The following is a description of a gene set: studied in species Homo sapiens from publication Schwartz JT, Bandyopadhyay S, Kobayashi SD, McCracken J, Whitney AR, Deleo FR, Allen LA (PMID 22986450) We demonstrated recently that both constitutive and FAS-triggered apoptosis of human neutrophils are profoundly impaired by Francisella tularensis, but how this is achieved is largely unknown. To test the hypothesis that changes in neutrophil gene expression contribute to this phenotype, we used human oligonucleotide microarrays to identify differentially regulated genes in cells infected with F. tularensis strain LVS compared with uninfected controls. In order to examine the effect of F. tularensis on the neutrophil transcriptome, we performed microarray expression analysis on human neutrophils treated with F. tularensis subsp. holarctica live vaccine strain (LVS). Genes up-regulated in comparison of control polymorphonuclear leukocytes (PMN) at 0 h versus PMN treated with F. tularensis vaccine at 6 h. Human Gene Set: GSE37416_0H_VS_6H_F_TULARENSIS_LVS_NEUTROPHIL_UP, and this is the list of marker genes: DUSP12, NSFL1C, ALG6, RNF135, NRDC, CD33, UBE2D1, EIF4E3, ARL6IP6, MSL3, FCGR3B, RESF1, NHS, RMI1, MANSC1, MCL1, CLEC4C, MIR21, SORT1, XRN2, APBB1IP, CEBPD, STX3, CCDC125, YWHAH, MPPE1, CREB5, SPINT1, TRERF1, UBR3, ZNF516 (zinc finger protein 516), DBI, PSMF1, HIPK3, H2BC9, MFSD14B, GNL3L, TRAPPC1, DPY19L3, FCGRT, GCNA, FAM8A1, RPS6KA3, USP48, HSPA8, GCA, USP32, RFNG, ICAM3, CX3CR1, MAP3K3, TMT1A, ZNF92, C1RL, GRAMD1C, MAP3K1, DPEP3, NRBF2, MTM1, KLHL8, PTRH2, NDUFB1, LMF2, ADAM19, PYGL, SULT1B1, ARHGAP1, IMPA2, NF1, GLUD1, BICD2, ATP13A1, INPP5B, ATF6, ZNF787 (NCBI Gene Id 126208), GAB1, KIAA0040, HK3, PARVG, CEP43, PTOV1, CHAC2, TCP11L2, CAPN1, WDFY3, TBC1D1, SCAMP1, TUBGCP3, SLC8B1, DEF8, ITGAL, CCDC126, TPST2, RASA1, RNF123, ITPR2, ZYG11B, RCBTB1 (RCC1 and BTB domain containing protein 1), SLC35A1, STK38, RPGRIP1, SMIM20, BTN3A1, TSC1, ANKRD44, RNF169, SECTM1, FCHO2, CASP2, ABHD18, AIF1, GAA, ITM2B, SMC1A, CAPRIN2, H2BC4, IRAG1, INTS3, C2CD2L, SLC25A44, VPS26B, PTPN18, KCTD21, USP6, DERA, TPM3, CZIB (CXXC motif containing zinc binding protein), JAK2, RAP1GAP2, CCNJL, FBXL5, SLC8A1, NASP, LIN37, NDUFB3, MMP25, CSAD, TLE4, CSNK1G3, INO80E, LRP10, APAF1, MSRB2, FCGR2C, SIN3B, ARSA, EVI5, EXOC6, NCKAP1L, CSNK2A1, FYB1, SLF1, PHB2, ZMPSTE24, PHKA2, TSPAN2, ACAP2, KIZ, SLC12A9, NELFA, TUBA1C, RABAC1, NUDT5, VCL, ATM, CARHSP1, DSN1, RNASET2, CD46, ARGLU1, DOP1B, COP1, EIF3A, BIN2, HSD17B11, FDFT1, CCPG1 (cell cycle progression 1), NBR2, TRIM24, ATP5F1E, CXXC1, LPCAT2, TMEM272, PIP4P2, MEGF6, SEC23A, ACTN4, CIAO2A, SGPP1, CMTM7, MPZL1, MVP, NCOR1, C14orf93, TBCB, EPS15, TSPO, ARHGAP9